Given this list of marker genes ANK2, FDX2, CCN4, ATP1B3, DIP2C, SATB2, DPP10 (NCBI Gene Id 57628), CCDC185, RELL1, GDI2, HTRA3, ZBTB18, FHIP2A, TSHZ3 (teashirt zinc finger homeobox 3), RNF38, LMNB1, SH3TC2, SUCO, CNTLN, LYPD1, RHEB, DDX47 (NCBI Gene Id 51202), CCDC103, SLITRK4, NR4A3, MAP4K4, PPP1R16B, FOXP4, C17orf58, ZNF827, ABCF2, EYA3 (EYA transcriptional coactivator and phosphatase 3), KANSL1L, WAC, PDIK1L, RNF222, CCDC152, TNPO3, HS3ST3A1, GXYLT1, FGD4, PHACTR3, OSBPL6, PLAAT5, PIF1, BCLAF3, BCL9, ZNF181, DCX, PDE4D, CSNK1G3, PAIP1, KLHL31, TEX2, ZNF302, ZFPM2, ELF3, SKIL, ZMYND11, CYB5B, ENTREP3, PPIP5K2, MARCKSL1, RICTOR, IGDCC4, NFIC, KLF12, BACH2, KMT2A, COL12A1, PDIA3, PSMF1, NR2C2, MTF2, RNLS, PHF19, MBNL1, MCTP2, ARL5A, PCBD2, HIPK3, PTPN1, CDK17, PMEPA1, C5orf47, G3BP2, MECP2, HS6ST3, FBXO34, KCNK9, CDK13, C1QTNF9, LIMA1, TNPO1, MKRN2, SRXN1, PHTF2, ZNF333, PALM2AKAP2 (NCBI Gene Id 5561), RAB10, TCF4, TNRC6B, ATXN1L, KIAA1549, HOXC4, MTARC2, KIF23, FBXO11, B3GAT1, ELMOD1, DNAJC27, EZH2, REST, KMT2D, PLEKHA7, RSBN1, CSMD1, here is a description of the gene set: Human Gene Set: MIR1301_3P_MIR5047 from publication Chen Y, Wang X (PMID 31504780) species: Homo sapiens Genes predicted to be targets of miRBase v22 microRNA hsa-miR-1301-3p, hsa-miR-5047 in miRDB v6.0 with MirTarget v4 prediction scores > 80 (high confidence targets).